Given this list of marker genes TES (testin LIM domain protein), PLSCR1, ABRACL, HDGF, INHBC, CSRP2, UGT8, PHACTR2, IL15RA, MEAK7, TRIM29, CCNB2, WARS1, DAPK1, ST8SIA1, GBP1, PSMG1, RSRC1, HEBP2, LILRB3, DSC2, FIRRM, AMD1, ATAD3A, UQCRH (ubiquinol-cytochrome c reductase hinge protein), TBPL1, DEF8, ENO1, GMPS, BTG3, PPP1CB, MALL, UGP2, MELK, PLEKHG1, LAD1, CYBB, GDF5, RBMS1, BIN1, CDCA8, CHST2, CEBPG, CSTB, C21orf91, CHI3L1, APOBEC3B, LPXN, GATAD2A, CHIC2, RAD54L, DUSP9, ATP1B3, MSN, GLIPR1 (NCBI Gene Id 11010), HJURP, IMPA2, IFNAR2, SOX10, BIRC2, MPZL1, RDX, NMB, AGFG1, IFRD1, PIMREG, CDK2AP1, TMCC2, FABP7, IDO1, HIF1A, H1-1, CDH3, JRKL, NFKBIE, DEFB1, PRIM2, TNFAIP3 (NCBI Gene Id 7128), PSAT1, MMP7, ITGB2, TTC7A, TMEM45A, FOXC1, RNF114, ST14, SLC2A6, MID1, MCM5, KATNA1, PKP1, PSME4, FZD9, LDHB, FSCN1, KCNK5, PGM1, TTYH1, ADAMTS7, SRSF7, KRT6B, GPSM2, CD180, YBX1, ATL3, SEM1, ASS1, TM4SF1, HK3, DUSP2, S100A10, GPRC5B, SLC35C1, LYN, PIM1, CLCN4, BCL2A1, MYBL2, GABRP, BLM, KRT7, EGFL6, NCK1, MEMO1, DYSF, FANCA, CCL5, SH3BP1, SYNCRIP, TNFRSF21, NF2, TBC1D1, CORO1C, TRPV6, NDRG1, PHGDH, P2RY6, ANLN, KIF1B, CX3CL1, BUB1, FAM20A, THEMIS2, PFKP, GPRIN2, CA9, ADM, UCHL3, PDZK1IP1 (NCBI Gene Id 10158), VGLL1, KIF2C, CENPA, SMCO4, CREB3L2, PEDS1, FDX1 (NCBI Gene Id 2230), RRP1, LAMP3, OPTN, DESI2, MCM6, PLTP, SERBP1, SOD2, STIL, SLC43A3, UCK2, SAMD4A, SRGN, MRAS (NCBI Gene Id 654181), MARCO, GAPDH (glyceraldehyde-3-phosphate dehydrogenase), GAPDHS, EML4, ODC1, SNN, PROM1, NCAPD2 (non-SMC condensin I complex subunit D2), CYBA, CDC20, SCHIP1, PADI2, FAM171A1, CTSV, KRT23, KCNN4, LGALSL, STEAP3, ILF2, PDXK, RCAN1, UBE2E3, NMI, CCNC, MYO10, FNDC3B, CYB5R2, PDCD5, CEP55, TOPBP1, CTSC, ASNS, NASP, LMO4, PDIA6, GOLT1B, RARRES1, MAPRE2, TMEM123, KRT16, SFT2D2, CTPS1 (CTP synthase 1), RAB6B, MTMR2, RSU1, LPIN1, EPHA2, CCL18, TMSB10, BCL11A (BCL11 transcription factor A), SLC2A5, TNF, TCN2, TTK, here is a description of the gene set: studied in species Homo sapiens from publication van 't Veer LJ, Dai H, van de Vijver MJ, He YD, Hart AA, Mao M, Peterse HL, van der Kooy K, Marton MJ, Witteveen AT, Schreiber GJ, Kerkhoven RM, Roberts C, Linsley PS, Bernards R, Friend SH (PMID 11823860) Breast cancer patients with the same stage of disease can have markedly different treatment responses and overall outcome. The strongest predictors for metastases (for example, lymph node status and histological grade) fail to classify accurately breast tumours according to their clinical behaviour. Chemotherapy or hormonal therapy reduces the risk of distant metastases by approximately one-third; however, 70-80% of patients receiving this treatment would have survived without it. None of the signatures of breast cancer gene expression reported to date allow for patient-tailored therapy strategies. Here we used DNA microarray analysis on primary breast tumours of 117 young patients, and applied supervised classification to identify a gene expression signature strongly predictive of a short interval to distant metastases ('poor prognosis' signature) in patients without tumour cells in local lymph nodes at diagnosis (lymph node negative). In addition, we established a signature that identifies tumours of BRCA1 carriers. The poor prognosis signature consists of genes regulating cell cycle, invasion, metastasis and angiogenesis. This gene expression profile will outperform all currently used clinical parameters in predicting disease outcome. Our findings provide a strategy to select patients who would benefit from adjuvant therapy. Human Gene Set: VANTVEER_BREAST_CANCER_ESR1_DN Down-regulated genes from the optimal set of 550 markers discriminating breast cancer samples by ESR1 expression: ER(+) vs ER(-) tumors.